The following is a description of a gene set: Human Gene Set: BROWNE_HCMV_INFECTION_18HR_DN The effect of human cytomegalovirus (HCMV) infection on cellular mRNA accumulation was analyzed by gene chip technology. During a 48-h time course after infection of human diploid fibroblasts, 1,425 cellular mRNAs were found to be up-regulated or down-regulated by threefold or greater in at least two consecutive time points. Several classes of genes were prominently affected, including interferon response genes, cell cycle regulators, apoptosis regulators, inflammatory pathway genes, and immune regulators. The number of mRNAs that were up-regulated or down-regulated were roughly equal over the complete time course. However, for the first 8 h after infection, the number of up-regulated mRNAs was significantly less than the number of down-regulated mRNAs. By analyzing the mRNA expression profile of cells infected in the presence of cycloheximide, it was found that a minimum of 25 mRNAs were modulated by HCMV in the absence of protein synthesis. These included mRNAs encoded by a small number of interferon-responsive genes, as well as beta interferon itself. Cellular mRNA levels in cytomegalovirus-infected cells were compared to the levels in cells infected with UV-inactivated virus. The inactivated virus caused the up-regulation of a much greater number of mRNAs, many of which encoded proteins with antiviral roles, such as interferon-responsive genes and proinflammatory cytokines. These data argue that one or more newly synthesized viral gene products block the induction of antiviral pathways that are triggered by HCMV binding and entry. from publication Browne EP, Wing B, Coleman D, Shenk T (PMID 11711622) Genes down-regulated in primary fibroblast cell culture after infection with HCMV (AD169 strain) at 18 h time point that were not down-regulated at the previous time point, 16 h. species: Homo sapiens, and this is the list of marker genes: DENND3, OBSL1, PCGF2, ANGEL1, ZNF688, INSIG1, MEGF8, CD5L, RBPMS, ALDOB, PNOC, DUSP1, ID2, WNT6, SFPQ, ANGPTL2, ARHGAP1, IFNG, ERVK-28, KCNK2, P3H3, EPPIN, GSTT2, FGF13, DHRS12, CACNA1A, SLC22A18, PCYT2, RAB3B, ASL, MYLK, CEMIP, VAMP4, VCAN, COL3A1, TGFB1I1, SURF1, THBS3, ABCA8, THBS1, DHFR, GP9, UGT2B7, HSD17B2, SEMA5A, MAZ, ZFR2, FAH, PLCD1, GATD3, MYC, FGF8, ADD3, GAS2, PDGFRB, GAS6, ANGPT1, CCDC85B, IGF2, PNLIP, COL6A2, ACSM3, TKT (transketolase), MSC, SNX17, ACOX2, RPS6KA2, S100A1, RRAS, LRRC32, COL6A1, PRKCB, DDT, TTLL1, P2RY10, LOXL1, ID1, RAD23A, UROS, SHH, ADH1A, NUMA1, KCNF1, BTBD2, HOXB1, CBFA2T3, PAMR1, SSPN, PDPN, LINC01565, CEP250, EPHB6, FYN, CCDC88C (NCBI Gene Id 57641), B2M, IRS1, RAC2, TNFRSF11B, CLIP3, PTGIS, YLPM1, VAMP5, FKBP8, NDUFB7, MAP2K5, TBCD, PTPRD, RASA4, DST, ALDH3B1, CTIF, ANXA2 (annexin A2), ETV6, GREM1, GPR176, EMILIN1, NIPAL3, PTEN, GNG11, NME3, GPR171, FADS1, ACTA1, IGHV4-34, CRHBP, SOCS1, DEFA1, SRI, RFX1, PTGER1, CZIB, TRAK1, SGCD, L3MBTL1, EPX, EXT1, TNS2, TRIOBP (NCBI Gene Id 23712), OCA2, POLD4, ITGAM, PLXNB1, TNIP1, PLXNA3, CD44, CIRBP, GLI3, RECK, LPCAT4, RIN2, PLXND1, CA12, PRKACG, SLC9A3, PSG6, CAVIN1, CDC42EP2, CDH6, GSTA4, LRRC17, ADAM12, GUCY1A2, AXL, MT3, TEAD1, ALDH7A1, CGB3, RBMS3, ZFPL1, CTSO, CARM1, APRT, OPLAH, RDH5, PSMB10, OGG1, VDR, WWP2, EPHX1 (epoxide hydrolase 1), TPM4, DMAC2L